The following is a description of a gene set: species: Homo sapiens The directed movement of heme, any compound of iron complexed in a porphyrin (tetrapyrrole) ring, into, out of or within a cell, or between cells, by means of some agent such as a transporter or pore. Human Gene Set: GOBP_HEME_TRANSPORT, and this is the list of marker genes: SLC48A1, PGRMC2, FLVCR1 (NCBI Gene Id 559), ABCB7 (ATP binding cassette subfamily B member 7), ABCC5, SLC46A1, FLVCR2, ABCB6, HPX